The following is a description of a gene set: Any process that activates, maintains or increases the frequency, rate or extent of myotube differentiation. Myotube differentiation is the process in which a relatively unspecialized cell acquires specialized features of a myotube cell. Myotubes are multinucleated cells that are formed when proliferating myoblasts exit the cell cycle, differentiate and fuse. Human Gene Set: GOBP_POSITIVE_REGULATION_OF_MYOTUBE_DIFFERENTIATION studied in species Homo sapiens, and this is the list of marker genes: MIR133B, CYP26B1 (NCBI Gene Id 56603), PIEZO1, MMP14, TBX1, MAPK14, CAV3, MIR133A1, ATP11A, MIR206, MTOR, MYOG, RBM24, MAML1, MIR1-1, MAMSTR, SMYD1